Given this list of marker genes Maea, Rmnd5b, Wdr26, Rmnd5a, Armc8, here is a description of the gene set: A protein complex with ubiquitin ligase activity that, in Saccharomyces cerevisiae, is involved in proteasomal degradation of fructose-1,6-bisphosphatase (FBPase) and phosphoenolpyruvate carboxykinase during the transition from gluconeogenic to glycolytic growth conditions. It appears to play a broader role in cellular homeostasis and development in other species. studied in species Mus musculus Mouse Gene Set: GOCC_GID_COMPLEX